Given this list of marker genes RRM1, CDCA3, MCM2, CDC20, TTK, PLK4, HMGB2, MCM4, PCLAF, HNRNPAB, HMMR, KIF20A (NCBI Gene Id 94421, kinesin family member 20A), METAP2, FOXM1, RFC3, CENPF, SNRPD1, ASPM, NUSAP1, CKAP2, RACGAP1, GMNN, CCT2, ZWINT, MRPL35, DTL, DLGAP5, FANCI, SMC4, RPA3, PRC1, NDC80, GINS1, PCNA, RFC4, FEN1, CCNA2, GINS2, CENPE, CDK1, CKS2, TYMS, BIRC5, CCNB2, SMC2 (structural maintenance of chromosomes 2), PTTG1, TOP2A, VRK1, SHCBP1, SLBP, here is a description of the gene set: species: Homo sapiens Neighborhood of CKS2 CDC28 protein kinase regulatory subunit 2 in the GNF2 expression compendium Neighborhood of CKS2 Human Gene Set: GNF2_CKS2